The following is a description of a gene set: Genes up-regulated in brain relapse of breast cancer. studied in species Homo sapiens Human Gene Set: SMID_BREAST_CANCER_RELAPSE_IN_BRAIN_UP We explored whether the five previously reported molecular subtypes in breast cancer show a preference for organ-specific relapse and searched for molecular pathways involved. The intrinsic gene list describing the subtypes was used to classify 344 primary breast tumors of lymph node-negative patients. Fisher exact tests were used to determine the association between a tumor subtype and a particular site of distant relapse in these patients who only received local treatment. Modulated genes and pathways were identified in the various groups using Significance Analysis of Microarrays and Global Testing. Bone relapse patients were most abundant in the luminal subtypes but were found less than expected in the basal subtype. The reverse was true for lung and brain relapse patients with the remark that absence of lung relapse was luminal A specific. Finally, a pleura relapse, although rare, was found almost exclusively in both luminal subtypes. Many differentially expressed genes were identified, of which several were in common in a subtype and the site to which the subtype preferentially relapsed. WNT signaling was up-regulated in the basal subtype and in brain-specific relapse, and down-modulated in the luminal B subtype and in bone-specific relapse. Focal adhesion was found up-regulated in the luminal A subtype but down-regulated in lung relapse. The five major molecular subtypes in breast cancer are evidently different with regard to their ability to metastasize to distant organ(s), and share biological features and pathways with their preferred distant metastatic site. from publication Smid M, Wang Y, Zhang Y, Sieuwerts AM, Yu J, Klijn JG, Foekens JA, Martens JW (PMID 18451135), and this is the list of marker genes: KRT16, PTX3, CXCL9, KCNK5, PRAME, FOLR1, BCL11A, PRKX, TNFRSF21, ST8SIA1, RARRES1, COL9A3, CENPN, VSNL1, SFRP1, CCKAR, TRIM29, MCM5, IGHV4-61, HOXA9, CDH3, EN1, EGFR, DLX5, IGHV3-23, KIFC1, EGFL6 (NCBI Gene Id 25975), CHST3, LDHB, SCRG1, IMPA2, GDF5, TMSB15A, MCM10, TTLL4 (NCBI Gene Id 9654), CP, WWTR1, MMP7, VGLL1, CENPF, ART3